The following is a description of a gene set: Human Gene Set: GOBP_REGULATORY_NCRNA_MEDIATED_GENE_SILENCING species: Homo sapiens A process in which an regulatory non-coding RNA molecule reduces expression of target genes. This can occur pre-transcriptionally by assembly of heterochromatin and prevention of transcription or co- or post-transcriptionally by targeting RNAs for degradation or by interfering with splicing or translation. This process starts once the inhibitory RNA molecule has been transcribed, and includes processing of the RNA such as cleavage, modifications, transport from the nucleus to the cytoplasm, loading onto the RISC complex, and the effect on transcription or translation., and this is the list of marker genes: MIR671, MIR557, MIR3180-2, MIR874, MIR194-1, MIR34C, MIR544A, TSN, MIR519B, MIR365A, MIR517B, MIR218-2, MIR553, MIR301B, MIR496, MIR26A1, MIR542, MALAT1, MORC1, MIR516A2, NCBP1, MIR519D, MIR892B, MIR1249, ELAVL1, MIR887, SPACA6-AS1, MIR449C, MIR18B, MIR23A, SPOUT1, MIR186, EZH2, MIR889, MIR135A2, MIR2355, MIR27B, MIR599, MIR600, MIR320D2, MIR766, MIR98, MIR626, MIR198, MIR1197, MIRLET7F1, ZC3H10, MIR548D1, MIR506, MIR101-1, MIR520G, MIR137, MIR550A1, MIR409, MIR125B1, MIR3677HG, MIR644A, MIR492, MIR383, MIR24-2, MIR124-2, MIR384, ASZ1, AGO3, MIR584 (microRNA 584), TERT, MIR374A, MIR10B, MIR17HG, MIR191, MIR5588, MIR875, MIR126, MIR518B, MIR675, MIR1271, MIRLET7G, MIR376A2, FXR1, MIR130B, MIR520C, MIR521-2, MIR1246, MIR205, MIR212, MIR1207, MIR3179-2, MIR103A1, MIR590, MIR452, AGO1, MIR29C, MIR133A1HG, MIR3180-3, STAU1, MIR16-1, MIR194-2, CELF1, MIR211, MIR382, TSNAX, MIR373, MIR541, MIR92A1, FBXO24, MIRLET7A3, ERI1, CARMN, MIR301A, TARBP2, MIR764, HNRNPA2B1, MIR564, MIR320E, MIR649, MIR31, MIR146A, MIR342, MIR631, EIF4G1, MIR133A1, DDX17, DICER1, MIR502, NCBP2, MIR556, MIR582, SRSF3, MIR1260B, ZFP36, MIR18A, MIR323A, NRDE2, MIR106A, MIR34B, MIR339, DDX6, MIRLET7A1, MIR376C, MIR891B, FKBP6, MIR33B, MIR517C, MIR483, MIR1-1, MIR518F, MIR192, MIR3074, MIR548P, MIR148A, MIR30C1, MIR539, MIR624, MIR548D2, MIR516B2 (microRNA 516b-2), MIR562 (microRNA 562), MIR1296, MIR520D, MIR1181, MIR377, MIR374C, MIR490, CNOT1, MIR523, MIR184, MIR505, MIR99A, MIR708, MIR574, MIR873, IL6, ADAR, MIR769, MIR3619, MIR133A2, RBM4, MIR26B, MIR329-1, MIR940, CACNA2D1-AS1, MIR340, MIR876, MIR450A1, MIR4500, MIR1306, METTL3, MIR200A, CNOT3, HELZ, MIR1180, C19orf84, HELZ2, EXD1, MIR654, TDRKH, MIR569, MIR328, ZSWIM8, MIR652, MIR93, MIR29B1, MIR200B, PIWIL3, MIRLET7F2, XIST, MIR3909, MIR1302-2, MIR206, DNM3OS (NCBI Gene Id 100628315), MIR3173, MIR324, PIWIL1, SND1, MIR1908, MIR153-1, MIR526B, MIR337, MIR369, MIR127, MIR744, MIR580, MIR597, MIR147B, MIR30B, MIR1183 (microRNA 1183), MIR548M, MIR612, MIR455, TUSC8, MIR526A2, MIR124-3, MIR4632, SRRT, MIR302B, MIR1255B1, SPEN, MIR802, MIR320B2, MIR607, MIR335, SMAD2, MIR28, FMR1, MIR376B, MIR656, MIR551B, CNOT6L, MIR136, MIR29A, MIR3180-5, SPOCD1, MIR423, MIR19A (NCBI Gene Id 406979), MAEL, MIR615, MIR1265, HNRNPU, MIR632, MIR379, MIR1227, MIR486-2, MIR196A1, MIR6869, MIR27A, HOXA10-AS, MIR9-2, ARB2BP (ARB2 family member B, pseudogene), MIR199B, MIR338, MIR760, MIR550B1, MIR449A, MIR448, MIR422A, MIR146B, MIR30A, MIR521-1, MIR202, MIR203A, MIR770, MIR642B, MIR608, MIR183, MIR92A2, MIR668, MIR618 (microRNA 618), MIR298 (NCBI Gene Id 100126296), CLP1, MIR196B, MIR133B, MIR3529, MIR765 (microRNA 765), MIR1827, MIR601, CNOT8 (NCBI Gene Id 9337), MIR659, ARB2A, MIRLET7D, MIR181C, MIR577, MIR575, MIR503, MIR939, TEX15, SMAD3, MIR616, MIR302D, MIR147A, MIR550A2, MIR129-1, MIR188, RIPK1, MIR181B1, MIR139, MIR936, MIR3148, NCBP3, PARTICL, MIR320C1, MIR1283-2, MIR938, MIR187, MIR586, MIRLET7A2, MIR214, MIR20B, MIR362, MIR944, MIR138-1, MIR761, MIR655, MIR296, MIR3591, MIR107 (microRNA 107), MIR515-1, MIR299, ZC3H7B, MIR548X2, MIR197, MIR224, ELOB, ELOC, MIR361, MIR524, MIR20A, MIR30C2, MAPT-AS1, MIR550A3, MIR648, MIR653, MIR1185-1, MIR148B, AGO2, RAN, MIR22, MIR320B1, MIR543, TRIM71, MIR663A, MIRLET7B, MEG3, PARN, CNOT10, MIR410, MIR3180-4, TNRC6A, MOV10L1 (Mov10 like RNA helicase 1), MIR150, MIR3120, MIR588, MIR181A1, DNMT3A, MIR372, TDRD6, MIR320C2, MIR300, MIR208B, MIR877, MIR450B, MIR130A, MIRLET7C, MIR491, PTENP1-AS, DNMT3L, MIR208A, LIN28B, MIR19B1, MIR6086, MIR638, MIR643, MIR374B, MIR105-2 (microRNA 105-2), MIR501, ZMPSTE24, MIR499A, TGFB1, MIR1251, DND1, MIR636, TDRD5, MIR371A, MIR34BHG, MIR346 (NCBI Gene Id 442911), MIR554, MIR9-2HG, MIR1912, AGO4, MIR583, PABPC1, MIR21, MIR181B2, MIR508, MIR576, TIAL1, MIR1275, DROSHA, MIR103A2, MIR609, MIR451B, MIR1302-4, MIR504, LINC-ROR, MIR4686, MIR891A, MIR486-1, MIR519A2, MIR3184, MIR30E, MIR449B, MIR145, SPIN1, MIR520F, MIR548H4, MIR323B, MIR520H, MIR497, DDX5, MIR514A1, MIR330, PNLDC1, MIR3661, MIR519A1, MIR125A, MIR552, TRUB1 (TruB pseudouridine synthase family member 1), MIR573, MIR488, PUM2, MIR605, MIR196A2, MIR549A, MIR19B2, MIR454, MIRLET7BHG, MIR204, MIR219A2, MIR509-1, MIR103B2, MIR1225, MIR141, MIR711, MIR181A2, MIR651, MIR217, HOTTIP, BCDIN3D, MIR190A, MIR581, MIR660, MIR411, MIR375, MIR219A1, MIR3142HG, MIR26A2 (microRNA 26a-2), MIR661, MIR4516, TENT2, MIR519C, MIR604, MIR1253, MIR1185-2, CNOT9, MIR215, MIR522, MIR500B, DDX4, NUP155, MIR425, MIR1237, MIR23AHG, MIR181D, MIR498, MIR650, MIR222, MIR1-2, MIR1287, MIR125B2, MIR526A1, DGCR8, MIR935, TUT4, MIR937, SMAD5-AS1, CNOT11, MIR182, MIR17, MIR493, MIR532, MIR924, MIR484, MIR7-1, MIR1178, MIR151A (NCBI Gene Id 442893), MIR185, MIR1283-1, MIR331, CNOT7, MIR548A3, MIR548AZ, MIR32, MIR639, MIR155, MIR367, MIR216A, MIR511, MIR381, MIR193A, MIR642A, MIR758, MIR1302-5, PRKRA, MIR548AA2, MIR378A, MIR429, MIR3065, MIR516B1, MIR548H2, MIR302E, MIR451A, MIR500A, MIR345, PIWIL2, MIRLET7I, MIR1277, MIR132, MIR199A2, MIR558, MIR142, MIR432, MIR485, MIR767, ZC3H7A, MIR520A, NEAT1, HOXB-AS3, MIR34A, EIF6, MIR572, MIR593, LIMD1, MIR518C, MIR525, TP53, CNOT2, PUM1, MIR9-3, MIR200C, HENMT1, TDRD12, PIWIL4, XPO5, MIR129-2, MOV10, MIR190B, MIR105-1, MIR221, MIR152, MIR106B (microRNA 106b), MIR16-2, MIR223, MIR33A, TNRC6C, MIR30D, MIR942, MIR193B, MIR518D, MIR934, MIR92B, MIR516A1, MIR499B, MIR219B, MIR7-2, MIR494, MIR489, MIR487B, MIR450A2, MIR302A, MIR633 (NCBI Gene Id 693218), WTIP, MIR320D1, MIR326 (microRNA 326), PUS10, MIR23B, MIR595, MIR135B, MIR25, MIR210, MIR29B2, MIR199A1, MIR122, MIR613, MIR15A, TNRC6B, SNIP1, STAT3, MIR424 (microRNA 424), EIF4ENIF1, MIR548AJ2, MIR518A1, MIR100, MIR329-2, MIR138-2, MIR657, MIR665, MIR548H3, MIR195, MIR662, MIR124-1, MIR140, MIR4286, MIR663B, MIR487A, MIR154, PLD6, LIN28A, MIR9-1, LL22NC03-63E9.3, MIRLET7E, GPAT2, MIR1224, MIR518E, TDRD9, HNRNPK, MIR15B, MIR101-2, MIR567, MIR203B, MIR621, MIR1208, AJUBA (ajuba LIM protein), MIR216B (NCBI Gene Id 100126319), MIR320A, EIF4E2 (eukaryotic translation initiation factor 4E family member 2), ZNFX1, MIR520B (NCBI Gene Id 574473), MIR578, MIR628, MIR302C, MIR10A, MIR885, MIR370, MIR495, MIR550B2, MIR517A, MIR412, GTSF1, MIR218-1, MIR640, MIR563, MIR143, MIR155HG, TUT7, MIR96, TDRD1, MIR527, MIR103B1, CNOT6, MIR676, MIR134, TDRD7, MIR135A1, MIR29B2CHG, MIR551A (NCBI Gene Id 693135), MIR149, MIR518A2, OIP5-AS1, MIR1298, MIR24-1, MIR592, MIR1307, SMAD1, MIR920, MIR548C, MIR4691, MIR363, MIR922, MIR128-1, MIR7-3, MIR589, MIR611, MIR137HG, MIR625 (NCBI Gene Id 693210), MIR144, MIR34AHG, MIR519E, MIR520E, BMP4, MIR99B, MIR433, MIR1226, DHX9